Given this list of marker genes Gsk3b, Dvl1, Adgra2 (adhesion G protein-coupled receptor A2), Lrp6, Reck, Wnt1, Axin1, Wnt3a, Dvl3, Lrrk2, Mamdc4, Ctnnb1, here is a description of the gene set: species: Mus musculus Mouse Gene Set: GOCC_WNT_SIGNALOSOME A multiprotein protein complex containing membrane-localized Wnt receptors and cytosolic protein complexes, which is capable of transmitting the Wnt signal. Contains at least a Wnt protein, LRP5 or LRP6, a member of the Frizzled (Fz) family, Axin and and a Dishevelled (DVL) protein.